Given this list of marker genes GOLGA2 (golgin A2), CDK1, BUB1B, INCENP, CCNB1, CENPE, BUB1, FBXW11 (NCBI Gene Id 23291), NINL, CDC20, TPT1, NUDC, ODF2, KIZ, STAG2, KIF20A (kinesin family member 20A), SPC24, RHOA, PPP2CA, BORA, PRC1, TUBG1, CDC14B, NDC80, PPP1R12A, FZR1, ECT2, CENPU, AURKA, TPX2, KIF2A, PPP2R1A, SGO1, CDC25C, WEE1, PAK1, RAB1A, PPP1CB, FBXO5, CDC25B, GORASP1, SSPOP, ROCK2, CLSPN, PLK1, ERCC6L, here is a description of the gene set: species: Homo sapiens PLK1 signaling events from publication Schaefer CF, Anthony K, Krupa S, Buchoff J, Day M, Hannay T, Buetow KH (PMID 18832364) Human Gene Set: PID_PLK1_PATHWAY